The following is a description of a gene set: The chemical reactions and pathways involving UDP, uridine (5'-)diphosphate. Human Gene Set: GOBP_UDP_METABOLIC_PROCESS species: Homo sapiens, and this is the list of marker genes: ENTPD7, UMPS, ENTPD4, CMPK1, ENTPD5, DHODH, CAD, AK9